Given this list of marker genes TMEM164, SLC39A7, AIFM2, KAT2B, ACLY, FTH1, SLC7A11, SLC25A1, SC5D, HDAC3, DHCR7, GPX4, NINJ1, SQSTM1, ADGRG1, NQO1, HMOX1, NFE2L2, here is a description of the gene set: species: Homo sapiens A programmed cell death characterized morphologically by the presence of smaller than normal mitochondria with condensed mitochondrial membrane densities, reduction or vanishing of mitochondria crista, and outer mitochondrial membrane rupture. Activation of mitochondrial voltage-dependent anion channels and mitogen-activated protein kinases, upregulation of endoplasmic reticulum stress, and inhibition of cystine/glutamate antiporter are involved in the induction of ferroptosis. This process is characterized by the accumulation of lipid peroxidation products and lethal reactive oxygen species (ROS) derived from iron metabolism. Glutathione peroxidase 4 (GPX4), heat shock protein beta-1, and nuclear factor erythroid 2-related factor 2 function as negative regulators of ferroptosis by limiting ROS production and reducing cellular iron uptake, respectively. In contrast, NADPH oxidase and p53 act as positive regulators of ferroptosis by promotion of ROS production and inhibition of expression of SLC7A11 (a specific light-chain subunit of the cystine/glutamate antiporter), respectively. Misregulated ferroptosis has been implicated in multiple physiological and pathological processes. Human Gene Set: GOBP_FERROPTOSIS